The following is a description of a gene set: Human Gene Set: GARGALOVIC_RESPONSE_TO_OXIDIZED_PHOSPHOLIPIDS_TURQUOISE_UP from publication Gargalovic PS, Imura M, Zhang B, Gharavi NM, Clark MJ, Pagnon J, Yang WP, He A, Truong A, Patel S, Nelson SF, Horvath S, Berliner JA, Kirchgessner TG, Lusis AJ (PMID 16912112) species: Homo sapiens Oxidized phospholipids are thought to promote atherogenesis by stimulating endothelial cells (ECs) to produce inflammatory cytokines, such as IL-8. In studies with mouse models, we previously demonstrated that genetic variation in inflammatory responses of endothelial cells to oxidized lipids contributes importantly to atherosclerosis susceptibility. We now show that similar variations occur in cultured aortic ECs derived from multiple heart transplant donors. These variations were stably maintained between passages and, thus, reflect either genetic or epigenetic regulatory differences. Expression array analysis of aortic EC cultures derived from 12 individuals revealed that >genes were regulated by oxidized phospholipids. We have used the observed variations in the sampled population to construct a gene coexpression network comprised of 15 modules of highly connected genes. We show that several identified modules are significantly enriched in genes for known pathways and confirm a module enriched for unfolded protein response (UPR) genes using siRNA and the UPR inducer tunicamycin. On the basis of the constructed network, we predicted that a gene of unknown function (MGC4504) present in the UPR module is a target for UPR transcriptional activator ATF4. Our data also indicate that IL-8 is present in the UPR module and is regulated, in part, by the UPR. We validate these by using siRNA. In conclusion, we show that interindividual variability can be used to group genes into pathways and predict gene-gene regulatory relationships, thus identifying targets potentially involved in susceptibility to common diseases such as atherosclerosis. Genes from the turquoise module which are up-regulated in HAEC cells (primary aortic endothelium) after exposure to the oxidized 1-palmitoyl-2-arachidonyl-sn-3-glycerophosphorylcholine (oxPAPC)., and this is the list of marker genes: NRG1, SLC25A25, CCDC82 (NCBI Gene Id 79780), CNKSR3, ZNF264, GAN, GPCPD1 (NCBI Gene Id 56261), NMRAL2P, GABARAPL1, TNFSF18, NAB2, RICTOR, HIPK3, ARRDC3, DIDO1, CLDN15, ERN1, EMP1, AHR, DUSP3 (NCBI Gene Id 284066), ACVR1, MYC, CLIP2, AGO2 (argonaute RISC catalytic component 2), MERTK (NCBI Gene Id 10461), SAMD8, PGF, SPOPL, SGK1, ZBTB34, KLF6, IPMK, SLC7A11 (NCBI Gene Id 23657), SPIRE1, CCDC117, AFF4, CLDND1, RRAGC (Ras related GTP binding C), CCNG2, PANK3, FBXO30, KLF10, DUSP1, FGFR1OP2, PRNP, NIPA1, ANKRD12, NECTIN3, C15orf39, ZNF697, ZFP36, NCOA3, RORA, HS6ST1, PIM3, CDC42EP2, GCLM, CFLAR, PTGR1, HYCC2 (hyccin PI4KA lipid kinase complex subunit 2), DLGAP1-AS2, CLIC2, PTP4A1, FOSL2, CREBRF, LINC00304, TIPARP, MAP1B, RIT1, JUN, SMG1, GDF15, PALM2AKAP2, TNPO1, SQSTM1, EGR1, SPRY2, ZNF627, ZCCHC2, MYCT1, DNAJB6, ARHGAP5 (NCBI Gene Id 394), SLC4A7